Given this list of marker genes TRAF1, NIT2, CCR4, CCDC141, TRIM13, TM7SF3, ALDH2, TLCD2, ARL6, FSHR, SPATS2, EXTL2, INSIG1, GAR1, NSMCE1, COPS7A, TNFSF10, PPT1, IFT70B, HDAC5, ALYREF, ARL6IP5, RNF130, P2RY14, FADS6, NME4, SLC22A16, DLD, XYLT2, FDFT1, ZBTB7B, STOM, COMMD10, PFN4, RFC1, MAFA, MKRN2, B3GNT2, SEMA4G, CDH1, SCTR, MCUB, RIDA, GNAQ, BCAP29, KLHDC1, CMAHP, XAF1, ANKRD45, MRPL36, CMC1, ARSA, HERC3, PRODH, NUDCD2, RIGI, MFN1, PCYT1A, SPNS3, AMD1, FHL3, PTGER4, DGCR6, MALT1, LDLR, EID1, HSD17B7, SESN3, PEX3, GET1, RRAGA, ARHGAP39, NPY, ENPP5, GATA3, IVD, KMO, PSMD14, EIF2AK2 (eukaryotic translation initiation factor 2 alpha kinase 2), OSGEP, CHL1, SELENOF, WDR35, BYSL, MPC1, TSC22D1, KCTD7, MACROD1, ARAP3, SLC39A11, CKS1B, UTP3, NAAA, RPL9, RPP14, RFC3, ERFE, FGR, EFTUD2, ANGPT1, DNAJC9, TMEM67 (NCBI Gene Id 91147), EMX2, EXOSC9, ITIH5, UCHL3, CCDC32, IL34, AMER3, LPXN, ITM2A, NIPSNAP1, CKB, TSPAN2, DCAF12L1, TOMM40L, PARP2 (NCBI Gene Id 10038), HSD17B4, CXCL12, DAP, GRN, RIOK2, NPL, EPCAM, SGSM2, CYB5B, CLNS1A, DIPK1B, BCCIP, SH3BP5 (SH3 domain binding protein 5), KDM4D, MTG1 (NCBI Gene Id 92170), ANXA2, AGPAT2, PTS, BCKDK, HMGCS1, MX1, NUP107, GAS8, MSMO1, NPHP4, TMEM41B, ATP6V1G3, RPL10A, CAMK2D (NCBI Gene Id 817), CCT8, PNO1, DTWD1, BLOC1S1, RNF182, SH3BP2, CCN2, CHSY1, PWP1, CDCA7, LMO2, RTN4IP1, CLIC4, CCR8, SCAMP1, PTGR2, ITGB3, IL17RB, RAPGEF3, here is a description of the gene set: species: Homo sapiens Human Gene Set: GSE27896_HDAC6_KO_VS_WT_TREG_DN Foxp3+ T-regulatory cells (Tregs) are key to immune homeostasis such that their diminished numbers or function can cause autoimmunity and allograft rejection. Foxp3+ Tregs express histone/protein deacetylases (HDACs) that regulate chromatin remodeling, gene expression and protein function. Pan-HDAC inhibitors developed for oncology enhance Treg production and suppression but have limited non-oncologic applications given their broad effects. We show, using HDAC6-deficient mice and WT mice treated with HDAC6-specific inhibitors, that HDAC6 inhibition promotes Treg suppressive activity in models of inflammation and autoimmunity, including multiple forms of experimental colitis and fully MHC-incompatible cardiac allograft rejection. Many of the beneficial effects of HDAC6 targeting are also achieved by inhibition of the HDAC6-regulated protein, HSP90. Hence, selective targeting of a single HDAC isoform, HDAC6, or its downstream target, HSP90, can promote Treg-dependent suppression of autoimmunity and transplant rejection. Genes down-regulated in T reg: HDAC6 knockout versus wildtype. from publication de Zoeten EF, Wang L, Butler K, Beier UH, Akimova T, Sai H, Bradner JE, Mazitschek R, Kozikowski AP, Matthias P, Hancock WW (PMID 21444725)